Given this list of marker genes PRC1, DGAT1, SGO2 (shugoshin 2), SNRPA (NCBI Gene Id 6626), LINC00839, KNL1, URB1, NCAPG, TOP2A, SLC35G2, BPNT2, DNAJC18, MTHFD2, TTK (TTK protein kinase), TTLL6, RAPGEF4, STAMBPL1, CHAF1A, ZNF37BP, AP2S1, PCBD1, BIRC5, NCAPH, PCLAF, MKI67, BOLA3, AURKA, C19orf48P, TRIM28, PEA15, GRAMD1A, RBIS, IQGAP3, TGFB1I1, RPL8, NECAB3, AFAP1L2, SPAG5, NPM1, RPS9, SLC7A1, PIP4P2, GMPS, ADAM19, SCNM1, ERCC1, RPIA, KIF20A, SLC39A14, FLT1, BUB1, GEMIN5, ASMTL, SLC16A1-AS1, FEZ1, CDKN3, ATP6V1C1, RIOX2 (ribosomal oxygenase 2), LMNB1, UBE2C, PRAF2, OLFML2A, TFAP2A-AS1, LRRC8C, ST3GAL5, KPTN, FBXO17, AFAP1L1, NOP16, SAE1, KSR1, RAB15, EIF4EBP1, TPX2, UAP1, KIF3C, CKS2, CENPU, PWWP2A, CENPE, PTP4A3, XPOT, BRIP1, DDIAS, MTA3 (metastasis associated 1 family member 3), CCNB2, HSPA9, BUB1B, NES, MLLT11, MZT2B, CHMP7, MICALL1, TNFRSF9, CENPF (centromere protein F), LARP1, DYSF (NCBI Gene Id 8291), MZT2A, RNASEH2A, ASPM, TPD52, ASF1B, GRINA, ARAP3, ANK2, ZGRF1, BARD1, SKA3, PTTG1, GJC1, FAM171B, DIPK1A, POLR3D, ATAD2, MAP3K20, DLGAP5, GTSE1, PAICS, WDR76 (WD repeat domain 76), CDC45, UHRF1, TGS1, MCM4, NSMAF, PRR11, SLC16A1, PCGF1, CHD1L, TK1, UBE2S, SPDL1, RFTN1, SHMT2, NUP210, NUSAP1, CCNB1, WDFY2, PIMREG, RRM2, SH3KBP1, SMC4, AKAP17A, CDC6, ANAPC1, HJURP, here is a description of the gene set: Human Gene Set: CHEMNITZ_RESPONSE_TO_PROSTAGLANDIN_E2_UP Genes up-regulated in CD4+ T lymphocytes after stimulation with prostaglandin E2. from publication Chemnitz JM, Driesen J, Classen S, Riley JL, Debey S, Beyer M, Popov A, Zander T, Schultze JL (PMID 16424048) species: Homo sapiens Many tumors, including Hodgkin's lymphoma, are associated with decreased cellular immunity and elevated levels of prostaglandin E(2) (PGE(2)), a known inhibitor of CD4+ T cell activation, suggested to be involved in immune deviation in cancer. To address the molecular mechanisms tumor-derived PGE(2) might have on primary human CD4+ T cells, we used a whole genome-based transcriptional approach and show that PGE(2) severely limited changes of gene expression induced by signaling through the T cell receptor and CD28. This data suggests an interference of PGE(2) at an early step of T cell receptor signaling: indeed, PGE(2) stimulation of T cells leads to inactivation of lck and reduced phosphorylation of ZAP70. Antiapoptotic genes escaped PGE(2)-induced inhibition resulting in partial protection from apoptosis in response to irradiation or Fas-mediated signaling. As a functional consequence, PGE(2)-treated CD4+ T cells are arrested in the cell cycle associated with up-regulation of the cyclin/cyclin-dependent kinase inhibitor p27(kip1). Most importantly, CD4+ T cells in Hodgkin's lymphoma show similar regulation of genes that were altered in vitro by PGE(2) in T cells from healthy individuals. These data strongly suggest that PGE(2) is an important factor leading to CD4+ T cell impairment observed in Hodgkin's lymphoma.